Given this list of marker genes DPM3, ANO5, TMEM43, TRAPPC11, HNRNPA1, FHL1, SGCA, CRPPA, LMNA, SYNE2, DAG1 (NCBI Gene Id 1605), EMD, POGLUT1, HNRNPDL, ACTA1, POMT2, SYNE1, here is a description of the gene set: Limb-girdle muscular dystrophy species: Homo sapiens Human Gene Set: HP_LIMB_GIRDLE_MUSCULAR_DYSTROPHY Muscular dystrophy affecting the muscles of the limb girdle (the hips and shoulders).